The following is a description of a gene set: Genes predicted to be targets of miRBase v22 microRNA hsa-miR-548ar-3p in miRDB v6.0 with MirTarget v4 prediction scores > 80 (high confidence targets). from publication Chen Y, Wang X (PMID 31504780) studied in species Homo sapiens Human Gene Set: MIR548AR_3P, and this is the list of marker genes: SDE2, DNAJC27, TET2, SREK1, TSPAN2, RNF19A, PPP6R3, MYEF2, SLCO4C1, FOXO3, LEPROT, ZFX, PSIP1, CNTNAP2, PCLO, ARPP19, ADSS2, FZD3, TMED4, RNPS1, TNPO1, ANGEL2, MTUS2, CSDE1, KLF7, CELSR1 (NCBI Gene Id 9620), ZNF333, PIAS2 (protein inhibitor of activated STAT 2), WDTC1, FBXW7, SERINC5, ANKRD11, SOWAHC, CDK13 (NCBI Gene Id 8621), P3R3URF-PIK3R3, SLC4A10, NEMF, PABPC5, FOXJ3, ZDBF2, PTEN, GPR137B, AHDC1, SV2B, BRWD1, PCDH11X, PGM2L1, TMEM33, TMED7, ABCC2, GTF2IRD2, FBXO22, SIK1, DKK3, FLT1, MICAL2, MED4, SLC6A11, SLC1A3, PLCH1, ZFPM2, HACD3 (3-hydroxyacyl-CoA dehydratase 3), USP48, UQCC6, HS3ST3A1, INHBB, SLC39A12, SCAI, DTD2, MED28, ZNF713, TOP2A, CALB1, PTPN12 (NCBI Gene Id 5782), FAM161A, TBP, IQCJ-SCHIP1, RAB31, CEP85L, ENSG00000275993, ATP11C, AMER1, UGT3A1, CSTF3, HERC4, TFRC, PHIP, DR1, PHF3, STXBP5, BTF3, SLC25A36, GNAO1, PKNOX1, KDELR3, MSI1, ECT2, WAPL, PHC3, GNS, ZMYND19, GPC4, RAPH1, REST, ONECUT2, ABHD6, NIPBL, ESYT2, ZPLD1, TGFBR3 (NCBI Gene Id 7049), LUC7L2, KAZN, RAD51AP1, ATRNL1, PPP4R3B, RGS22, MAF, KLF9, LTBP1 (latent transforming growth factor beta binding protein 1), SRCIN1, HACE1, PCDH7, TP53INP1, UBR2 (ubiquitin protein ligase E3 component n-recognin 2), NINL, ATXN3, JAKMIP3, DYNC1LI2, PTBP3, ZYG11B, GABPB1, SPRED1, TCF20, BCORL1, VPS37A, COMMD3-BMI1, HTR5A, ARID4A, PDK3, G3BP2, ARL8B, GEMIN2, TMEM236, MCC, STAM2 (NCBI Gene Id 51453), FAM76A, JAKMIP2, RPGRIP1L, ELAVL1, ADAMTSL3, EZR, MTX3, SMAD4 (NCBI Gene Id 4089), ATXN1, BOLL, SEC62, C4orf51, PAG1, HCFC2, SPOPL, ITPRID2, MIER3, SLC39A10, QKI, NAA16, VSTM4, CSK, MSMO1, ADAM22, EGFL8, ATRX, TRAPPC8, ZNF148, FGFR1OP2, FNIP2, INTS15, LYRM7, HYPK, RGS3, GABRG1, EVI5, FNDC3A, PYCR1, ZDHHC21, TPR, CNTN4, UTP23, ADAMTS5, NEURL3, ADPRH, SAMD8, TAB2, PTBP2, IER3IP1, APOL6, OPRM1, HNRNPUL2, PIK3CG, CDYL, TRUB1, CDC14A, FMC1-LUC7L2, UGGT1, RNF14, CD47, GNB2, RPS6KB1, ZFHX4, GFRA1, UBE2G1, TP53BP1, ACKR3, SLC26A4, CNEP1R1, PBX2, PIGN, B3GAT1, KIF2A, ATXN7, INO80D, COX15, SPIN4, ELK4, TAF9B, SLC44A5, BEX2, PAK2, DENND4C, ERBIN, TDG, TRAPPC1, TAPT1 (NCBI Gene Id 202018), PAK4, KLHL28, TMED5, TOR1A, TNRC18 (trinucleotide repeat containing 18), SYNDIG1L, PHF6, SLC25A24, CNOT6L, RUFY2, AMPH, ZNF91, HECTD2, WDR89, GUCY1B1, ZNF280C, TET1, STRBP, EIF1, NRK, SCML1, ETNK1, TSTD2, ZBTB41, EBF2, ZNF658, ZCCHC10, LRRTM3, ENOPH1, MINDY2, ATP2A2, SERTAD2, GALNT1, C1orf131 (NCBI Gene Id 128061), TRMT10A, IREB2, TSPAN16, PAIP1, KANSL1, TRPM7, PDE10A, DIDO1 (NCBI Gene Id 85362), PRRC1, TNFSF13B, ZNF229, PLEKHB2, FAM169A, APLF, OTX2, CHST14, PI4KB, VPS13C, NSD2, ADH5, NNT, CDCA7, EIF4E, GTF2A1, NUAK1, ATXN7L1, SOX9, FGG, SH3GL2, TM9SF2, KLHL15 (NCBI Gene Id 80311), ZSCAN30, SP3, RPP30 (ribonuclease P/MRP subunit p30), PIP4K2A, TXNRD1, BCLAF1, BZW1, ACVR1C, CDK19, PCBP2, KANSL1L, HERC1, FTHL17, KDM1B, CCDC186, PMS1, CNTN1, BMPR2, PCGF5, MFAP3L, SOCS6, SASS6, DSG2, ZEB1, ITPR1, TBL1XR1, EPC1, COL19A1, ADAM10, GABRB1, RGS4, WNK3, CDK6, PNPLA4, OSBPL8, TMEM169, SGCZ, PHF20L1, ZNF681, CTTNBP2, PARP16, CCSER1, SULT1C4, RAPGEF5, PCGF3, PIK3R3, FTO, TRMT5, TRAM2, SPIRE1, SPINK7 (serine peptidase inhibitor Kazal type 7), ZNF711, MEF2A, GPAM, RNF207 (ring finger protein 207), CDC42BPB, PXYLP1, STK39, GTF2IRD2B, IPMK, NHLRC2, ACVR2B, MEX3D, MTPAP, HLF, PDE7B, CCAR1, RNF19B, TENT4B, PLPPR1, SLC1A1, PDS5B, TNRC6B, DSC2, MMAB, ATF2, WDR47, ARHGAP6, MPZL2, ALKBH5, SESN3, ZBTB20, TLNRD1, CXCR4 (NCBI Gene Id 93405), NUDT12, TOMM20, ZMYND11, ZNF281, EDEM3, DGKH, RAB27B, DDX3X, MEX3C (mex-3 RNA binding family member C), MMP2, XRN2, DHH, CLASP2, PNISR, ZFYVE28, RNF168, TRPC5, SLC4A5, NEK7, ITGAV, CAVIN4, GSPT1, ZNF264, FAM149B1, GADD45A, NTN4, FJX1, PIK3R1, ZC3H12C, PAPOLA, SLC22A16, C3orf70, ASB15, RNF38, B4GALT6, CUL3, CENPH, USP31, KMT2D, RAB22A, SERBP1, ZFAND5, MACF1, ACYP2, CCNYL1, POU4F1, ENTPD1, MTDH, PCNA, LPP, USP38, ANKRD55, ZFAND4, PIK3CB, PURB, CNBP, GEMIN5, TEAD1, DMD, NFAT5, VASP, CCL28 (C-C motif chemokine ligand 28), MAP7 (NCBI Gene Id 9053), SELENOF, APELA, IFT81, FAM120A, ZBTB14, ADIPOQ, TMEM167B, RNF217, MSL2, OTUD6B, SLC2A13, DCC, GPR22, NR3C2, SLC30A5, VHL, ZNF106, IKBIP, UXS1, ZBTB44, PGM3, LATS1, ZFAND3, CXXC4, ARHGAP21, SARAF, PEX13, THUMPD1, FAM3C, RNF2, N4BP2L1, ZFHX3, TAOK1, PIAS1, WASHC3, PCBP4, GCNT1, CPNE8, LCP2, U2SURP, FERMT2, NAV3, PCBP1, GKAP1, MYO5A, PPP3R1, OSM, GPR63, CREB5, CFAP418, MAP4, CHCHD7, PIKFYVE, MEX3B, KCNC1, PATZ1, ZNF260, RSBN1, VMA21, USP33, TAF4, RAD23A, ATF7IP2, MTF1, IKZF2, BCL11A, GRIA3, CPNE3, GUCY1A1, ZNF484, EHMT1, B3GLCT, SLC4A4, ZFR, TOP2B, WDR17, PPM1D, SKIL, SCHIP1, ZNF275, TTC39B, AFG2A, SHPRH, GCSAML, MAP3K2, KBTBD8 (kelch repeat and BTB domain containing 8), ARL6IP1, MECP2 (methyl-CpG binding protein 2), CLU, WASF1, TMEM245, LINC02801, MYO1B, PLAGL1 (PLAG1 like zinc finger 1), HLTF, ADGRB3, TTPA, SUB1, SMNDC1, FZD4, FLI1, GPR85, BCOR, HAPLN1, ZNF569, MAFB, BBS5, SNRPD1, NF1, XPO4, ENPP2, RBFOX1, ANKRD33B, CFHR5, TPBG, VEZT, PPM1B, CHRAC1, ATL1, CAMTA1, OTULINL, ARK2N, CDCA4, NDUFC2-KCTD14, ALS2, MOB1B, NEXMIF, CALM1, MPHOSPH9, SGIP1, BRWD3, ST18